The following is a description of a gene set: Binds to and increases the activity of guanylate cyclase in response to a change in calcium ion concentration. studied in species Homo sapiens Human Gene Set: GOMF_CALCIUM_SENSITIVE_GUANYLATE_CYCLASE_ACTIVATOR_ACTIVITY, and this is the list of marker genes: GUCA1C, GUCA1ANB-GUCA1A, GUCA1B, GUCA1A, NCS1, RCVRN